The following is a description of a gene set: Human Gene Set: HARALAMBIEVA_PBMC_FLUARIX_AGE_50_74YO_CORR_WITH_28D_MEM_B_CELL_RESPONSE_AT_28DY_LATE_GENE_EXPR_INDIVID_GENE_MODELS_PRED_PEAK_B_CELL_ELISPOT_RESP_NEGATIVE studied in species Homo sapiens Genes negatively correlated with memory B cell response at 28d in peripheral blood mononuclear cell in seniors (50-74) after exposure to Fluarix, time point 28D. Comment: D: Late gene expression individual gene models (predicting peak B cell ELISPOT response) for module 11 (D, MSE=2.062) BACKGROUND: Studies suggest that the recall-based humoral immune responses to influenza A/H1N1 originates from activated memory B cells. The aim of this study was to identify baseline, early and late blood transcriptional signatures (in peripheral blood mononuclear cells/PBMCs) associated with memory B cell response following influenza vaccination. METHODS: We used pre- and post-vaccination mRNA-Seq transcriptional profiling on samples from 159 subjects (50-74years old) following receipt of seasonal trivalent influenza vaccine containing the A/California/7/2009/H1N1-like virus, and penalized regression modeling to identify associations with influenza A/H1N1-specific memory B cell ELISPOT response after vaccination. RESULTS: Genesets and genes (p-value range 7.92E(-08) to 0.00018, q-value range 0.00019-0.039) demonstrating significant associations (of gene expression levels) with memory B cell response suggest the importance of metabolic (cholesterol and lipid metabolism-related), cell migration/adhesion, MAP kinase, NF-kB cell signaling (chemokine/cytokine signaling) and transcriptional regulation gene signatures in the development of memory B cell response after influenza vaccination. CONCLUSION: Through an unbiased transcriptome-wide profiling approach, our study identified signatures of memory B cell response following influenza vaccination, highlighting the underappreciated role of metabolic changes (among the other immune function-related events) in the regulation of influenza vaccine-induced immune memory. from publication Haralambieva IH, Ovsyannikova IG, Kennedy RB, Zimmermann MT, Grill DE, Oberg AL, Poland GA (PMID 27317456), and this is the list of marker genes: SNORD102, DAB2, RAI1, CRB2, SYNJ1, A1BG, IGSF10 (immunoglobulin superfamily member 10), ZNF682, NFE2L3, SNORA3B